The following is a description of a gene set: Human Gene Set: MIR4691_3P from publication Chen Y, Wang X (PMID 31504780) studied in species Homo sapiens Genes predicted to be targets of miRBase v22 microRNA hsa-miR-4691-3p in miRDB v6.0 with MirTarget v4 prediction scores > 80 (high confidence targets)., and this is the list of marker genes: MAFG, APC, ARAP2, CACNA1B, PYGB, CYRIA, MBD1, FAM53C, MED27, ARHGAP24, DCLK1, MYOF, TVP23A (NCBI Gene Id 780776), SLC45A4, PDIK1L, SUSD6, NKIRAS1, DYRK1A, DUXA, GRIK2, SS18, KIF21A, HNRNPK, LMX1A, MTURN, FOXG1, CDH20, GARS1, EXTL3, RAB1A, PPP1R1B, HSD3B2, MED21, NUDT10, DGAT2L6, ZNF711, F2RL2, HTR1F, BCL9L, RUNX2, ALKBH1, FAM53B, JRK, SPRY1, AZI2, PTH2R, PTBP2, UBE2E2, PSMB5, DLGAP3, ERMN, PHF20L1, PRICKLE2, DHODH, JAG2, NF2, EIF4G1, ACO2, ZMYND11, BCAT1, MMP11, HIPK1, PLEKHG4B, MCMDC2, KPNA1 (NCBI Gene Id 3836), KY, SREK1, GATA6, GOSR2, SEC24C, SFMBT2, ZFAND6, DIO2, ABHD16A, ZBTB34, MARCHF5, KLF1, PDS5B, TRIT1, TBC1D4, GLG1, MYO1E, FCER2, PARN, CACNG6, ISOC2, TCF4, RBPJ, MNT, DNER, CTNND1, CAMK2A, ENTPD6, HS3ST4, DLX1, BHLHE22